Given this list of marker genes SLC27A4, PODXL, GRXCR2, CLCA1 (NCBI Gene Id 1179), MYO1H, SLC38A4, CLRN1, SPEF1, SLC26A2, SYTL1, MYO1D, CDHR5, MYO1E, STARD10, JAM3, TGFB1, USH1C, CA9, TPRN, CDHR2, ATP6V1E1, MYO7B, ANKS4B, S100P, IZUMO1R, IQGAP2, CTNNB1, WWOX, CALML4, MYO7A, MYO1G, ATP6V1A, CBLIF, CRB1, ATP6V1B2, DPEP1, CUBN, ANGPT1, AQP5, PROM1, VIL1, TBC1D10A, MYO6, SLC7A5, DCXR, AMN, SLC10A2, ENPP7 (ectonucleotide pyrophosphatase/phosphodiesterase 7), TEK, GRXCR1, MUC20, PDGFA, MYO1A, PROM2, ICAM2, FSCN3, CLIC4, MTTP, ATP6V1B1, ITGB3, FMN2, OTOP1, MYO1C, SLC6A6, MYO1F, MYO1B (myosin IB), CEACAM1, ESPN, FCRL3, RDX, FSCN1, VCAM1, FOXA1, BBS2, NHERF1, SPN, RAPGEF3, MSN, IFT20, EZR, PDGFRA, EXOC4, SLC7A8, CD302, HYAL2, PLEKHG6, SLC7A11, PDPN, CD44, AOC3, CEACAM20, FABP2, LRRK2, PTPRH, PDZK1, ITGAV, AMN1, here is a description of the gene set: Human Gene Set: GOCC_MICROVILLUS species: Homo sapiens Thin cylindrical membrane-covered projections on the surface of an animal cell containing a core bundle of actin filaments. Present in especially large numbers on the absorptive surface of intestinal cells.